The following is a description of a gene set: This COVID-19 pathway has been created by a combination of computational inference from SARS-CoV-1 data (https://reactome.org/documentation/inferred-events) and manual curation, as described in the summation for the overall SARS-CoV-2 infection pathway.<br><br>Nucleoprotein, the most abundant viral protein expressed during infection, is found in the host cell cytosol, the nucleus and plasma membrane. After phosphorylation and sumoylation it di-/tetramerizes and is moved to the Golgi, the virion budding site. studied in species Homo sapiens Reactome Pathway: Maturation of nucleoprotein_9694631 part of: Translation of Structural Proteins, and this is the list of marker genes: CSNK1A1, PARP6, PARP14, PRMT1, SRPK2, GSK3B, PARP4, PARP10 (NCBI Gene Id 84875), PARP16, UBE2I, SUMO1, GSK3A, PARP8, N, SRPK1, PARP9